Given this list of marker genes Gphb5, Zfp36l1, Fgf18, Ube2d2a, Gpr174, Btla, Epb41l2, Rdh19, Tmed5, Onecut2, Ift70a1 (NCBI Gene Id 78802), Zmynd11, Esr2, Stx11, Bltp3a, Sh3bgrl, Strbp, Pou2f2, Ccl8, Tmem45a2, Nalf1, Runx2, Malt1, Rbpj, Ptprb, Tmco3, Gask1b, Jagn1, Ppargc1a, Greb1l, Slc25a37, Dpp4, Prdm1, Dnajc19, Camta1 (NCBI Gene Id 75679), Cyp3a59, Smurf2, Ro60, Dcaf1, Klhl31, Amz2, Zdhhc21, Khdrbs1, Ppp1r21, Strc, Adam23, Rora, Zfp385b, Nudt7, Irx3, Lrp3, Lrrc74b, Galnt1 (NCBI Gene Id 14423), Calu, Pax6, Efnb3, Vcan, Selenop, Jph3, Olig2, Sephs1, Aurkb, Fut9, Slc39a8, Gabrb1, Dnlz, Rps6ka6, Aldh8a1, Sorcs1, Cyp4f14, Csmd1, Arhgef9, Mpzl3, Zbtb2, Cnep1r1, Zc3h6, Higd2a, Isg20, Slc18a1, Prkd1, Cwf19l1, Cfap91, Tmem52b, Cyp3a25, Yap1, Nol4l, Plekhb2, Zfp352, Atp5mc1, Sult2a8, Slc38a7, Pacsin2, Bmp6, Mfsd4b2, Sgms1, Dmd, Gm14295, Or5b95, Uvssa, Zfp131, Gatc, here is a description of the gene set: Mouse Gene Set: MIR_6969_3P studied in species Mus musculus Genes predicted to be targets of miRBase v22 microRNA mmu_miR_6969_3p in miRDB v6.0 with MirTarget v4 prediction scores > 80 (high confidence targets). from publication Chen Y, Wang X (PMID 31504780)